The following is a description of a gene set: Human Gene Set: KEGG_MEDICUS_PATHOGEN_SALMONELLA_SPVD_TO_TNF_NFKB_SIGNALING_PATHWAY species: Homo sapiens Salmonella SpvD to TNF-NFKB signaling pathway. Pathway ID: N01118. Pathway type: Pathogen. Pathway class: nt06516 TNF signaling. Pathway Definition from KEGG: SpvD -| XPO2 -> (KPNA1+KPNA3) -> NFKB, and this is the list of marker genes: RELA, KPNA3, NFKB1, CSE1L, KPNA1